The following is a description of a gene set: Any process involved in the activation of any of the steps of the lectin pathway of the complement cascade which allows for the direct killing of microbes and the regulation of other immune processes. species: Mus musculus Mouse Gene Set: GOBP_COMPLEMENT_ACTIVATION_LECTIN_PATHWAY, and this is the list of marker genes: Colec11, Fcnb, Masp2, Colec10, Mbl2 (NCBI Gene Id 17195), Mbl1, Fcna, Masp1, Serping1, Krt1, A2m